The following is a description of a gene set: species: Homo sapiens Transcription regulation during the cell cycle is crucial for ensuring genes are expressed at the right time and in the correct amounts, coordinating key processes like DNA replication, mitosis, and cell division. In our study, Genes whose expression fluctuates during the cell cycle (pVal < 0.05) and peaks in early G1 (eG1) in K562 Human Gene Set: PULVER_FOREY_CELLCYCLE_PEAKING_EG1, and this is the list of marker genes: TYSND1, EP400P1, ARHGAP17, SLC38A7, STAG3, C4orf3, CPTP, RARS1, RNF145, ZNF708, TBRG1, ZCCHC2, B3GNT6, MAGEB2, PLEK, KYNU, PAPLN, TPRG1L, FKBP11, CCNYL1, CAMSAP3, SLC35B3, ARIH1, SNN (NCBI Gene Id 8303), VPS39, TBCEL, NAPSA, ERMP1, CAPS, TRIM35, PEAK3, GNGT1, F8, LGALS4, OVGP1, LIMK1, PLEKHN1, SP140L, ZNF699, CSF3R, ITGB3, CCDC102A, SELPLG, P2RX5, ZC3H12A, CAMSAP2, LLGL2, ZNF772, NDFIP1, PATL2, PACSIN3, TOB1, ZMYND10, PIK3C2B, PTGDR2 (prostaglandin D2 receptor 2), CRPPA, STRADA, ZNF676, EFHC2, TTC8, SLC35D2, LRRC75B, TSPAN17, MYO1F, EFEMP2, HIP1, OSCP1, DIRAS1, VENTX, PML, GBP2, ZNF587, ZDHHC11, MTMR12, CD84, ZNF467, DHFR2, FAM170B, PPL, KLF2, MSRB1, CTBS, PDLIM2, CA12, SLC2A4, ADTRP, SNX21, ZNF487, LRRC8E, C11orf71, ZNF543, CFAP298, MAP10, VMAC, MYO15B, NXF1, MASP2, CEP19, BLCAP, DOK4, KYAT1, BTK, BSN, CCDC136, PHKG2, ZNF432, HPGD, GRB7, NPFFR2, PTCH2, PGBD1, FAM13A, SIK2, ZNF557, NCKAP5L (NCBI Gene Id 57701), IL4R, KCNN1, ABCB9, FBXO17 (NCBI Gene Id 79967), TNFAIP2, BCL2L11, VSIR, B3GALNT2, DISC1, LPAR2, ZNF474, TBC1D7, TATDN3, FNDC10, LFNG, ABHD15, OCEL1, WDR47, SNX19, PHETA1, DRC7, IDS, WDR55, PYGM, DCN, MXRA7, NEU4, PDE11A, ZNF622, TMEM106A, MMP14, PIK3C3, TNFRSF4, HEATR5A (NCBI Gene Id 387979), CALB1, ZNF585B, PRKCG, ATOSB, A1BG, ANKRD45, LRRC73, NES, CDKN1C, TMEM104, SLC35G2, SLC49A3, ACVR1, SIRT7, SLC23A3, VDR, LSMEM1, LCAT (NCBI Gene Id 3931), PLEC, ITGAM, PLAUR, CCDC9B, TUSC2, MED20 (mediator complex subunit 20), MAGEB1, B3GNT8, SLAMF6, ALAS1, FOSL2, CKAP4, HID1, PROSER1, CDKL2, VTN, CMTM6, CAB39L, PI16, SYNPO, ZNF140, PLEKHO1, MTRF1L, NPRL2, ZNF493, LAMTOR5, ZBTB43, ITPRIPL2, TMEM184A, NKIRAS1, HOXB5, SPINT1, NBEAL1 (neurobeachin like 1), KCNK13, TCAP, APOL2 (apolipoprotein L2, NCBI Gene Id 23780), ITGA3, CTNNB1, MAPK15, ADGRE2, LGALS12, MYG1, DRICH1, LRP1, ITGAX, NMNAT1, DENND1C, RNF146 (NCBI Gene Id 81847), KLHL7, AMIGO1, TIMMDC1, ZSCAN30, EPB41L1, ADM5, PSEN2, GTF2H5, GNPDA1, TP53INP1, SARDH, MYOM1, GSDMB, MON1B, SWAP70, GM2A, CPT2, NAA60, FAM227A, SOSTDC1, GLMP, ZNF235, NFKB2, ZNF461, SPEG, ZNF566, SNCG, ICAM3, TRAPPC2L, SLC25A29, CCDC154, TBC1D10A, URB1-AS1, NBPF3, OLFM3, SERPINH1, CFAP263, GPR132, RAB34, ZNF596, DNM1, ERICH1, ESPNL, MAP3K12, RHBDF2, LINC02897, ALDH1A1, IGF1, GMIP, ZNF260, P2RX6, SEMA4A (semaphorin 4A), SIGLEC10, MRPS30, SMIM14, SHF, ZNF211, CXorf38, PRR13, CRB2, DLL4, CFP, FAM117B, PLD2, ZNF17, ZNF383, SLC35E4, ZMYM3, DCAF4L1, RINL, ZNF776, SNAP23, CEBPD, SNX18, INTS6, NFKBIB, SAP30L, PRR29, ZDHHC8, CAPN11, PITX3, PPARA (peroxisome proliferator activated receptor alpha), RTCA, AASDHPPT, VPS26C, AKR7A3, DDX53, SLC6A19, DSCR4, FBXO27 (NCBI Gene Id 126433), LZTS3, IFT43, EFCAB12, KRCC1, PLEKHA2, TRIM38, DBNDD1, FLNC, LY6G6C, KLHDC8B, ZNF717, NYNRIN, AHNAK2, BMPR2 (NCBI Gene Id 659), TMEM184C, ZCCHC24 (NCBI Gene Id 219654), MCF2L2, HSPBAP1, CASP10, PROCR, FAM174A, NUDT3, NLGN3, AOC2, CFI (complement factor I), RSKR, IL7R, ATP8A2, KRBA1, MAGI2, APOBR, SYNC, RMDN2, RAB3D, PLAT, TRIM29, SLC37A3, SPRING1, PTPN6, VGF, OAZ2, FZD4, COMMD5, RAG1, DYNLL2, SERPINF1, PIP4K2C, TENM1, CBLB, ALOX5, CHP2, MMRN2, BTBD19, NDN, RALA (RAS like proto-oncogene A), TTC38, VWA1, IFNAR2, CLDN9, PSPH, FBXL20, SLC35F2, AOC3, JRKL, C2CD2L, NMD3, CELF5, PDGFB, ZNF264, CD53, SLC2A12, CMYA5, SDHAF4, FRAT1, MAP4K3, FOXD4, UNC93B1, SEC61A2, PABPN1L, GSTO2, GSTM3, TRIM25, COX19, TRAF5, PAQR8, PALMD, CALM1, HOXB6, ZNF529, MMP15, DKKL1, LEAP2, HDAC11, FNDC11, FBXL17 (NCBI Gene Id 64839), ARHGAP12, TNFSF10, SPIRE2, WIPI2, AZU1, LRRC25, ZNF516, RCOR2, SELENOW, KLHL30, RAB9A, CCDC80, CLDN15, PLA2G4C, RNF11, WASL, SERAC1, MYL5, HELZ2, DNASE1L1, RAB11FIP4, ZGLP1, TNFSF12, MARVELD1 (MARVEL domain containing 1), FBXL2 (NCBI Gene Id 26008), AKIRIN1, LYZ (NCBI Gene Id 4069), CCDC62, LTK (leukocyte receptor tyrosine kinase), ZNF431, VASN, SETD7, CTNS, APOBEC3D, KCNC3 (NCBI Gene Id 57363), POLN, GPD1, ARHGEF3, C12orf76, SH3YL1, MROH6, ZNF320, ZFAND2A, SH3BP1, DISP2 (NCBI Gene Id 85455), SLC35F6, SV2A, LAPTM5, RASGRP4, PLPPR2, DQX1, SPIRE1, ANGPTL4, ZBTB1, CNKSR1, SSC4D, TMEM120B, SLC26A11, SULT1A2, KIAA1191, SMIM29, ADI1, TSPOAP1, GPR157, NKX3-2, DCUN1D5, H1-1, TUBAL3, CNPY4 (canopy FGF signaling regulator 4)